Given this list of marker genes STON1, PRG4, SOWAHC, RNF182, HSPA4L, WEE1, PHLDB2, LAPTM4A, HOOK1, SPAG17, SET, CRIP2, LYSMD2, TIAM1, RRAGD, EHBP1, TPH1, CD200, CD38, GBP4, PCDH11X, METTL8, IL7, SLC18B1, AGPAT4, ILF2, FBXO30, PARP8, SKAP2, PRL, SLC27A2, GPR62, BTBD8, PPM1B, SLC27A5, MBNL3, GCA, CLVS2, RGS12, FRMD4A, GPR155, ANGPTL1, YPEL2, TBC1D2B, FAM110C, CYBRD1, LRRC8D, AATK, PLA2G4F, TMTC3, FMNL2, SERPINE2, ENSG00000286190, CAGE1, DYNLT2, ZNF365, HAPLN1, CPD, PLA2G2D, SPIN4, GNB5, SVIP, KCNMB4, MEGF9, VSIG4, ARMCX2, KIF5C (kinesin family member 5C), IGF2R, DMD, CLDN12, TGFBR1, DYNLL1, CCR6, PPP1R21, ROBO1, CDKN2A, AXDND1, COL7A1, HTR1F, ARHGAP20, SEMA5A, FRRS1L, ECM1, SPATA24, FNBP1L, XDH, REL, RGS16, IL1RL1 (NCBI Gene Id 9173), HTR5A, GNB4 (NCBI Gene Id 59345), FAM131A, TATDN2 (NCBI Gene Id 9797), KIT, CACNG5, IGLL1, SNAI2, MCUB, LRRC75A, FTX, ATP6V0E2, FAR1, ALMS1, ALDH18A1, PPM1L (protein phosphatase, Mg2+/Mn2+ dependent 1L), RHCG, MREG, MARCKS, GPR85, BCAS1, RAB3IP (NCBI Gene Id 64325, RAB3A interacting protein), CBX3, ALOX15, DLG3, CRIPTO, SLC7A10, LAYN, DHDH, LNPK, SLC5A3, TMEM65, TBC1D4, IKZF4, FABP1, BRINP3, IFT80 (NCBI Gene Id 57560), CCNO, PHIP, ZCCHC8 (zinc finger CCHC-type containing 8), TUBB2B, CILK1, ZC2HC1A, DNAJC12, SPNS2 (NCBI Gene Id 124976), CYTH3, KRT13, ZNF420, AMZ1, NT5DC3, NTN4, PFN2, AIRN, GUCY1B1, GMCL1, MYO3B, CNR1, RB1, FGF13, LRRCC1, SHTN1, NDRG4, PACSIN1, C3orf70, VAV2, PRKAG2, REEP5, TMEM202, GGH (NCBI Gene Id 8836), SLC12A2, RPS6KB1 (ribosomal protein S6 kinase B1), GSAP, VEZT, TTC9C, ECEL1, ZFP41, TSPAN6, SWAP70, NDFIP2, SLC22A9, CDH26, MS4A1, NIBAN1, GDA, HSD3B7, FRMD6, TSPAN8, DCST2, ADARB2, IGF1R, DNAH5, SOX3, NR2E3, DNPH1, MEIS2, GPR15, PRUNE1 (prune exopolyphosphatase 1), SLIT2, RIMKLA, C1QL3, TBX21, IRF6, ACY3, IFI44, OSR2, IKZF2, TEX55, MACROH2A2, KRT24 (keratin 24), EGR2, here is a description of the gene set: studied in species Homo sapiens from publication Hill JA, Feuerer M, Tash K, Haxhinasto S, Perez J, Melamed R, Mathis D, Benoist C (PMID 18024188) Genes up-regulated in comparsion of ActTregTGF versus ActCD4TGF (see Fig. 1 in the paper for details). The transcription factor Foxp3 is usually considered the master regulator for the CD4+CD25+ Human Gene Set: GSE7460_TREG_VS_TCONV_ACT_WITH_TGFB_UP